The following is a description of a gene set: Human Gene Set: TRAVAGLINI_LUNG_ALVEOLAR_FIBROBLAST_CELL from publication Travaglini KJ, Nabhan AN, Penland L, Sinha R, Gillich A, Sit RV, Chang S, Conley SD, Mori Y, Seita J, Berry GJ, Shrager JB, Metzger RJ, Kuo CS, Neff N, Weissman IL, Quake SR, Krasnow MA (PMID 33208946) studied in species Homo sapiens, and this is the list of marker genes: SAMHD1, ZDHHC14, SRGN, FMO3, FGFR4, COL13A1, PMP22, HMCN1, SLC38A5, PER2, DUSP1, TCF21 (transcription factor 21), SVEP1, CAMK2N1, SGCD, SPTBN1, LMCD1, SERINC5, ADH1B, S1PR2, MFAP4, ZYX, MAOB, FN1, MYH10, FBLN5, LTBP4, FBP1, ABCA6, KCNK6, LRRN3, RGS3, LIMCH1, IGSF10, AOC3, ARHGAP20, LSAMP, CASP4, LBH, SERPING1, PRELP, PLEKHH2, MME (NCBI Gene Id 4311), ICAM1, RGCC, TMEM119, CES1, RARRES2, TMEM176B, OLFML3, KANK4, CD44, EMP2, SLIT2, VEGFC, MMP19, SRGAP1, GRIA1, DOCK4, KIFC3, MOXD1 (NCBI Gene Id 26002), CDO1, LITAF, UCP2, ADARB1, SLC29A1, PLXDC2, CCBE1, CD36, PRG4, MACF1, MAMDC2, MMP2, FMO2, PIEZO2, SPINT2, MCOLN2, ALDH1A1, COL8A1, NEBL, WNT2, EFCC1 (NCBI Gene Id 79825), CHRDL1, LAMA4, IL15RA, LUM, USP53, TMEM37, NRP1, CYP3A5, GDF10, DHRS3, CDH11 (NCBI Gene Id 1009), ROBO2, TGM2, DYNC2LI1, NUAK1, CD82, CDH13, DKK3, G0S2, PDGFRA, ABI3BP, COL6A6, SERPINB9, FIBIN, SGCG, CCN1, CCN2, PGAP2, ISLR, CD14, CYP7B1, CYP4B1, MCOLN3, NCAM2, IRS2, LINC00968 (NCBI Gene Id 100507632), ULK4, NABP1, TMEM176A, NTNG1, PDLIM2, PTGIR, ANXA1, ZNF106, ENPP2, SLC1A5, ANGPT1, SAT1, ANO1, CD8A, HIVEP3, ABCA8, INMT, MRC2, OR7E47P, TIMP3, F11R, TMEM108, HSD11B1, CMKLR1, FHL1, DUSP6, ITGA2, DST, CASP12, A2M, MYADM, COLEC12, GPM6B, MAL, SNCA, ADAMTS8, SCN7A, COL6A3, BMP5, S100A4, TMT1A, ITGA8, GPC3, ELMO1, LIMS1, NPNT